The following is a description of a gene set: Processing of Intronless Pre-mRNAs Human Gene Set: REACTOME_PROCESSING_OF_INTRONLESS_PRE_MRNAS studied in species Homo sapiens, and this is the list of marker genes: NCBP1, NUDT21, NCBP2, PAPOLA, SYMPK, CSTF2, CPSF2, CSTF2T, CLP1, CSTF3, CSTF1, CPSF6, CPSF1, CPSF7, PCF11, WDR33, FIP1L1, PABPN1, CPSF4, CPSF3